Given this list of marker genes Ccnd1, Pxn, Btc, Cdkn1b, Hras, Bcar1, Dok1, Khdrbs1, Ubb, Socs3, Gpnmb, Rasa1, Nrg3 (NCBI Gene Id 18183), Erbb4, Ccne1, Rps27a, Ptpn1, Cbl, Erbb2, Khdrbs3, Crk, Hif1a, Arap1 (NCBI Gene Id 69710), Cdk4, Khdrbs2, Egfr, here is a description of the gene set: studied in species Mus musculus Reactome Pathway: Signaling by Non-Receptor Tyrosine Kinases part of: Signal Transduction electronically inferred by orthology from the curated human pathway This event has been computationally inferred from an event that has been demonstrated in another species.<p>The inference is based on the homology mapping from PANTHER. Briefly, reactions for which all involved PhysicalEntities (in input, output and catalyst) have a mapped orthologue/paralogue (for complexes at least 75% of components must have a mapping) are inferred to the other species.